The following is a description of a gene set: electronically inferred by orthology from the curated human pathway species: Mus musculus This event has been computationally inferred from an event that has been demonstrated in another species.<p>The inference is based on the homology mapping from PANTHER. Briefly, reactions for which all involved PhysicalEntities (in input, output and catalyst) have a mapped orthologue/paralogue (for complexes at least 75% of components must have a mapping) are inferred to the other species. Reactome Pathway: Intra-Golgi traffic part of: Intra-Golgi and retrograde Golgi-to-ER traffic, and this is the list of marker genes: Alpi, Nsf, Cog8, Cog7, Rab39, Cyth4, Rab30, Arf1, Snap29, Cyth3, Cyth1 (cytohesin 1), Rab36